The following is a description of a gene set: Human Gene Set: HP_ABNORMAL_MORPHOLOGY_OF_THE_LIMBIC_SYSTEM Any structural anomaly of the limbic system, a set of midline structures surrounding the brainstem of the mammalian brain, originally described anatomically, e.g., hippocampal formation, amygdala, hypothalamus, cingulate cortex. Although the original designation was anatomical, the limbic system has come to be associated with the system in the brain subserving emotional functions. As such, it is very poorly defined and doesn't correspond closely to the anatomical meaning any longer.. Abnormal morphology of the limbic system studied in species Homo sapiens, and this is the list of marker genes: RAD51, FGFR2, DNA2, GABRG2, POU4F1, CPA6, PCDH19, GABRA1, NEK1, TUBB3, GRM7, ZEB2, NR2F1, RNU4ATAC, DPYSL5, SLITRK2, SCN9A, CNPY3, VPS13A, TUBA1A, CLCN3, MTHFD1, RNU4-2, NTN1, EML1, COQ4, SLC35A2, CNTN2, MACF1, CARS2, ATP1A3, TCF4, VPS51, VAX1 (NCBI Gene Id 196056), KDM5A, GRIN1, STAMBP, OSTM1, CPLX1, SCN1A, CEP85L, SCN1B, DNAL4, DCC, NDE1, ABCA7, KDM4B, BICRA, TBC1D24, RAP1B, SCN2A, CAMTA1